Given this list of marker genes CFH, ECI2, CHMP2A, GJA1, RHPN1, DENND10, ARHGDIB, TMEM158, ICAM1, LYSMD3, GAL, DCTN3, LBH, MORC3, B9D2, LMNB1, MRPL57, MVP, COX19, TRPT1, SMARCD1, VPS54, ANP32A, GNB3, TBC1D19, BLCAP, CHFR, TRPS1, FURIN, PLAGL2, POLR2E, ACSBG1, SUSD6, DAPP1, SUGT1, ILKAP, GNPDA1, SLC39A1, MIDN, DALRD3, AK1, ADRA1A, TMEM14C, PHLDA1, FXYD5 (FXYD domain containing ion transport regulator 5), PIK3CA, EGR1, PTPN1, TMED3, NDUFB11, APP, PLA2G12A, MANF, P4HA1, ERP44, MYD88, SDCBP2, PRPSAP2, CMTM3, RPS6KB1, LRRC8C, SGK1, VIM, TFEB, ATOSB, CTTN, NEAT1, JMJD8, IGFBP4, TSC22D4, CNN2, TXK, KLF6 (KLF transcription factor 6), MAFF, RALBP1, MVB12A, RRAD, ACVR2A, POFUT1, ARF5, NDUFC2, SLC2A1, GM2A, SEC61G, PRR12, FRYL, PRDX5, MDP1, ALPK2, CKS2, PNPO, IER3, PML, FNDC3A, UQCRFS1, CPD, FLT3LG, CHPT1, GRAMD1A, HK1, IL17RA, NT5E, COL19A1, CHUK, CCDC88C, ARAF, SATB1, YPEL3, LDLRAD4, CHD7, PLEKHO1, GMPR2, RAB3IP, SYP, RAB18, IER5, KAT2B, CYRIB, F13B, LAMTOR3, INTS6L, SDF4, DDX4, MAF, CREB3L2, CXCR3, COG6, CISH, SUCLG1, CTNNA1, ALDH7A1, CFAP36, CD44, UBALD2, CFP, HNRNPC, LPP, SSX2IP, ST8SIA2, CHAF1B, LDHA, PLEC, TCN2, SLC25A19, IFFO2, AGPAT3, CTSK, SPHK1, KCTD10, ABCA1, TIMP2, GIPC2, TXN (thioredoxin), MARCHF6, SEC24D, EPB41L2, CTLA4, LCK, RIOK3, TBC1D10B, ITM2C, INHBA, ZDHHC20, LZTR1, SS18, RALGAPA1, PITPNM1, RAC2, CASP8, TLX3, CTDNEP1, VPS33B, CTSA, UBLCP1, CTSB, LAT, SMPD2, MOB3B, LGALS3BP, ALDH3A2, TSHZ1, GLRX, MST1, ATP6V1D, UQCC2, PLTP, TM2D3, DGKA, TALDO1, FLOT1, IRF4, HYCC1, MAP3K14, KAZALD1, HIF1A, NAT9, DOCK1, B4GALT1, PAGR1, MKRN3, here is a description of the gene set: Regulation of lineage potential and transcriptional priming by Ikaros. New insight is provided into a bivalent regulation of lineage priming in the HSC and its lympho-myeloid restricted progeny the LMPP by the lymphoid lineage-determining factor Ikaros Whereas Ikaros is responsible for the activation of a cascade of lymphoid expression programs and for the establishment of lymphoid potential from the HSC to the LMPP it is also responsible for the repression of stem cell and erythroid genetic programs that are incompatible with further lineage restrictions emanating from the LMPP from publication Ng SY, Yoshida T, Zhang J, Georgopoulos K (PMID 19345118) Genes up-regulated in IKZF1 knockout: hematopoietic stem cells versus megakaryo-erythrocyte progenitors. species: Homo sapiens Human Gene Set: GSE15330_HSC_VS_MEGAKARYOCYTE_ERYTHROID_PROGENITOR_IKAROS_KO_UP